Given this list of marker genes TNFSF18, GREM1, CCN3, HMGB1, ANO6, CXCL17, NINJ1, MOSPD2, CX3CR1, S100A14, CXCL12, MICOS10-NBL1, CXCL10, CCR2, PLA2G7, DEFB124, SLIT2 (slit guidance ligand 2), CCR1, NBL1, CCL1, APP, CREB3, DUSP1 (NCBI Gene Id 1843), CCL5, FPR2, LYN, SERPINE1, DEFB131A, S100A7, LGMN, SLAMF8, AIF1, here is a description of the gene set: Any process that modulates the frequency, rate, or extent of monocyte chemotaxis. species: Homo sapiens Human Gene Set: GOBP_REGULATION_OF_MONOCYTE_CHEMOTAXIS